Given this list of marker genes TNFRSF18, THBS4, EFNA1, ENPP2, SRCIN1, IL11, ANGPT1, CD80, IL6, ADAM17, HES1, ABL1, FGF7, FGFR3, VEGFA, GPRC5B, IFNG, PARP14, IL18, KIT, PTPN1, TNK2, ERBB4, NEDD9, BANK1, CNTF, EFNA5, DOK7, TGFB1, LACRT, PARP9, LILRA5, JAK2, IL12A, PIBF1, UNC119, IL15, OSM, ARL2BP, CSPG4, CASS4, FGF10, IFNL1, RIPK2, VEGFB, LIF, IL31RA, ABI1, ARHGEF2, NRG1, IL20, CSF1R, IL21, FLT3, CTF1, TNFSF18, ANGPT4, here is a description of the gene set: Human Gene Set: GOBP_POSITIVE_REGULATION_OF_PEPTIDYL_TYROSINE_PHOSPHORYLATION Any process that activates or increases the frequency, rate or extent of the phosphorylation of peptidyl-tyrosine. studied in species Homo sapiens